The following is a description of a gene set: Human Gene Set: CAO_BLOOD_FLUMIST_AGE_05_14YO_7DY_DN from publication Cao RG, Suarez NM, Obermoser G, Lopez SM, Flano E, Mertz SE, Albrecht RA, García-Sastre A, Mejias A, Xu H, Qin H, Blankenship D, Palucka K, Pascual V, Ramilo O (PMID 24495909) species: Homo sapiens Genes down-regulated in blood 7d vs 0d in children (0.5-14y) after exposure to FluMist, time point 7D. Comment: ~80% of cohort were white, ~50/50 Female:male BACKGROUND: Live attenuated influenza vaccine (LAIV) and trivalent inactivated influenza vaccine (TIV) are effective for prevention of influenza virus infection in children, but the mechanisms associated with protection are not well defined. METHODS: We analyzed the differences in B-cell responses and transcriptional profiles in children aged 6 months to 14 years immunized with these 2 vaccines. RESULTS: LAIV elicited a significant increase in naive, memory, and transitional B cells on day 30 after vaccination, whereas TIV elicited an increased number of plasmablasts on day 7. Antibody titers against the 3 vaccine strains (H1N1, H3N2, and B) were significantly higher in the TIV group and correlated with number of antibody-secreting cells. Both vaccines induced overexpression of interferon (IFN)-signaling genes but with different kinetics. TIV induced expression of IFN genes on day 1 after vaccination in all age groups, and LAIV induced expression of IFN genes on day 7 after vaccination but only in children < 5 years old. IFN-related genes overexpressed in both vaccinated groups correlated with H3N2 antibody titers. CONCLUSIONS: These results suggest that LAIV and TIV induced significantly different B-cell responses in vaccinated children. Early induction of IFN appears to be important for development of antibody responses., and this is the list of marker genes: RASGRP4, ASB16-AS1, PPP1R8, BMF, RSC1A1, MYBPH, TBC1D17, FGFBP3